The following is a description of a gene set: Heme degradation Mouse Gene Set: REACTOME_HEME_DEGRADATION studied in species Mus musculus, and this is the list of marker genes: Slco1b2, Slco2b1, Abcc2, Gsta2, Gsta5, Gsta1, Blvra, Ugt1a5 (NCBI Gene Id 394433), Fabp1, Alb, Gsta13, Gsta3, Hmox1, Ugt1a1, Abcc1 (ATP-binding cassette, sub-family C member 1), Blvrb, Ugt1a2, Hmox2